The following is a description of a gene set: studied in species Homo sapiens Human Gene Set: GOMF_MRNA_3_UTR_AU_RICH_REGION_BINDING Binding to a region containing frequent adenine and uridine bases within the 3' untranslated region of a mRNA molecule or in pre-mRNA intron. The ARE-binding element consensus is UUAUUUAUU. ARE-binding proteins control the stability and/or translation of mRNAs., and this is the list of marker genes: ELAVL4, FXR1, CPEB1, CPSF1, KHSRP, ILF3, MEX3D, EXOSC8, EXOSC9, EXOSC4, ZC3H12A, EXOSC7, CPEB3, RBM24, APOBEC1, AGO2, ELAVL3, ZFP36L1, HNRNPD, ZFP36, CPEB2, ZFP36L2, ARID5A, RBMS3, HNRNPA0, NUDT21, ELAVL1, TIA1 (TIA1 cytotoxic granule associated RNA binding protein), DHX36